Given this list of marker genes HNRNPK, BMPER, DOHH, BAZ1B, CLIP2, GTF2I, WWOX, MYL11, RAB34, LZTR1, ELN, BUB3, BUD23, CSGALNACT1, MUSK, RAP1B, EPHB4, HDAC8, DHPS, TMEM270, PIGN, STX1A, TRIP11, NCF1, BUB1B, TAF6, ATN1, ARSL, RAD21, BRD4, BUB1, CEP57, FGFR3, FIG4, TBL2, RFC2, FKBP6, STAG1, SMC3, DHCR7, METTL27, TRIP13, VPS37D, EIF4H, LBR, GTF2IRD2 (NCBI Gene Id 84163, GTF2I repeat domain containing 2), GTF2IRD1, DNAJC30, VAC14, ADARB1, NIPBL, COG8, GPC6, LIMK1, ODC1, SMC1A, TXNDC15, here is a description of the gene set: studied in species Homo sapiens Nuchal translucency is the sonographic appearance of subcutaneous accumulation of liquid in the back of the fetal neck in the first trimester of pregnancy (11-14 gestational weeks of pregnancy). Human Gene Set: HP_INCREASED_NUCHAL_TRANSLUCENCY Increased nuchal translucency